Given this list of marker genes ARGLU1 (arginine and glutamate rich 1), CD40 (NCBI Gene Id 958), CIRBP, RARB, WSB1 (NCBI Gene Id 26118), RALGDS, GIMAP4, SPOCD1, here is a description of the gene set: Human Gene Set: GARGALOVIC_RESPONSE_TO_OXIDIZED_PHOSPHOLIPIDS_LIGHTGREEN_DN Genes from the lightgreen module which are dn-regulated in HAEC cells (primary aortic endothelium) after exposure to the oxidized 1-palmitoyl-2-arachidonyl-sn-3-glycerophosphorylcholine (oxPAPC). Oxidized phospholipids are thought to promote atherogenesis by stimulating endothelial cells (ECs) to produce inflammatory cytokines, such as IL-8. In studies with mouse models, we previously demonstrated that genetic variation in inflammatory responses of endothelial cells to oxidized lipids contributes importantly to atherosclerosis susceptibility. We now show that similar variations occur in cultured aortic ECs derived from multiple heart transplant donors. These variations were stably maintained between passages and, thus, reflect either genetic or epigenetic regulatory differences. Expression array analysis of aortic EC cultures derived from 12 individuals revealed that >genes were regulated by oxidized phospholipids. We have used the observed variations in the sampled population to construct a gene coexpression network comprised of 15 modules of highly connected genes. We show that several identified modules are significantly enriched in genes for known pathways and confirm a module enriched for unfolded protein response (UPR) genes using siRNA and the UPR inducer tunicamycin. On the basis of the constructed network, we predicted that a gene of unknown function (MGC4504) present in the UPR module is a target for UPR transcriptional activator ATF4. Our data also indicate that IL-8 is present in the UPR module and is regulated, in part, by the UPR. We validate these by using siRNA. In conclusion, we show that interindividual variability can be used to group genes into pathways and predict gene-gene regulatory relationships, thus identifying targets potentially involved in susceptibility to common diseases such as atherosclerosis. from publication Gargalovic PS, Imura M, Zhang B, Gharavi NM, Clark MJ, Pagnon J, Yang WP, He A, Truong A, Patel S, Nelson SF, Horvath S, Berliner JA, Kirchgessner TG, Lusis AJ (PMID 16912112) studied in species Homo sapiens